Given this list of marker genes RNF43, ARSA, MST1, BMP6, BRCA1, DZIP1L, BRCA2, PSAP, PTPN3, PKHD1, STK11, HFE, GPR35, SEMA4D, TCF4, ROS1, here is a description of the gene set: species: Homo sapiens Human Gene Set: HP_BILIARY_TRACT_NEOPLASM A tumor (abnormal growth of tissue) of the biliary system. Biliary tract neoplasm